The following is a description of a gene set: Aberrant expression of the human homeobox-containing proto-oncogene TLX1/HOX11 inhibits hematopoietic differentiation programs in a number of murine model systems. Here, we report the establishment of a murine erythroid progenitor cell line, iEBHX1S-4, developmentally arrested by regulatable TLX1 expression. Extinction of TLX1 expression released the iEBHX1S-4 differentiation block, allowing erythropoietin-dependent acquisition of erythroid markers and hemoglobin synthesis. Coordinated activation of erythroid transcriptional networks integrated by the acetyltransferase co-activator CREB-binding protein (CBP) was suggested by bioinformatic analysis of the upstream regulatory regions of several conditionally induced iEBHX1S-4 gene sets. In accord with this notion, CBP-associated acetylation of GATA-1, an essential regulator of erythroid differentiation, increased concomitantly with TLX1 downregulation. Coimmunoprecipitation experiments and glutathione-S-transferase pull-down assays revealed that TLX1 directly binds to CBP, and confocal laser microscopy demonstrated that the two proteins partially colocalize at intranuclear sites in iEBHX1S-4 cells. Notably, the distribution of CBP in conditionally blocked iEBHX1S-4 cells partially overlapped with chromatin marked by a repressive histone methylation pattern, and downregulation of TLX1 coincided with exit of CBP from these heterochromatic regions. Thus, we propose that TLX1-mediated differentiation arrest may be achieved in part through a mechanism that involves redirection of CBP and/or its sequestration in repressive chromatin domains. from publication Riz I, Akimov SS, Eaker SS, Baxter KK, Lee HJ, Mariño-Ramírez L, Landsman D, Hawley TS, Hawley RG (PMID 17213805) Selected gradually up-regulated genes whose expression profile follows that of HBZ in the TLX1 Tet On iEBHX15-4 cells (pro-erythroblasts). Mouse Gene Set: RIZ_ERYTHROID_DIFFERENTIATION_HBZ species: Mus musculus, and this is the list of marker genes: Mcm5, Nkx2-5 (NCBI Gene Id 18091), Hmgb1, Prox1 (prospero homeobox 1), Tbx2, Tmpo, Nr4a2, Basp1, Nr2f1, Mcm4, Papola, Cbx7, Zfp46, Mpl, Sox1, Pou3f2, Hoxb13, Aff1, Gata5, Gcm2, Nr5a1, Pou2f3, Tal2, Sox4, Sox18, Six2, Eya2, Bard1, Kdm5a, E2f8, Pou3f3, Mcm7, Etaa1, Cbx3 (NCBI Gene Id 12417), Fosb, Tfap2c, Cux1